Given this list of marker genes Itga3, Muc20, Sh3gl3, Col2a1, Ptpn1, Gab1, Ranbp10, Tns4, Cbl, Hras, Rab4a, Shc1, Gga3, Stam, Ranbp9, Col24a1, Crk, Ptpn2, Grb2, Arf6, Col5a3, Itga2, Ubb, Hgf, Spint1, Col11a2, Hgfac, Lama4, Hpn, Ptk2, Rps27a, here is a description of the gene set: electronically inferred by orthology from the curated human pathway This event has been computationally inferred from an event that has been demonstrated in another species.<p>The inference is based on the homology mapping from PANTHER. Briefly, reactions for which all involved PhysicalEntities (in input, output and catalyst) have a mapped orthologue/paralogue (for complexes at least 75% of components must have a mapping) are inferred to the other species. species: Mus musculus Reactome Pathway: Signaling by MET part of: Signaling by Receptor Tyrosine Kinases